Given this list of marker genes NFATC3, PDCD4, MIR26A1, NFATC1, SHH, MIR100, MIR21, MIR15B, MIR199B, MECP2, RBPMS2, MIR221, PDGFB, DNMT1, RCAN1, FGF9, HEY2, PRDM6, EREG, MED28, NFATC2, FOXO4, HEY1, here is a description of the gene set: studied in species Homo sapiens Human Gene Set: GOBP_NEGATIVE_REGULATION_OF_SMOOTH_MUSCLE_CELL_DIFFERENTIATION Any process that stops, prevents, or reduces the frequency, rate or extent of smooth muscle cell differentiation.